Given this list of marker genes WDR43, UBTFL1, DEK, POLR2K, SF3B1, UBTFL6, EIF2AK3, LYAR, DHX33, MACROH2A1, SMARCA5, NCL, CREBBP, SMARCB1, PHF8, MACROH2A2 (NCBI Gene Id 83738), PIH1D1, PRR7, FLNA (NCBI Gene Id 8272), ERBB2, NOP53, SIRT7, NOL11, DDX21, DEDD, ATF4, UBTF (NCBI Gene Id 7343), SMARCA4, ERCC6, HEATR1, ACTR6, IPPK, UTP15, WDR75, BNC1, CARM1, MARS1, MTOR, ZMPSTE24, POLR2L, BAZ2A, MYO1C, RASL11A, MAF1, DDX11, PWP1, MYBBP1A, BAZ1B, here is a description of the gene set: Any process that modulates the frequency, rate or extent of transcription mediated by RNA polymerase I. species: Homo sapiens Human Gene Set: GOBP_REGULATION_OF_TRANSCRIPTION_BY_RNA_POLYMERASE_I